The following is a description of a gene set: studied in species Homo sapiens Any process that activates or increases the frequency, rate or extent of gap junction assembly. Human Gene Set: GOBP_POSITIVE_REGULATION_OF_GAP_JUNCTION_ASSEMBLY, and this is the list of marker genes: IRX3, ACE2, HOPX, CAV1, CNTNAP2, TBX5, AGT